The following is a description of a gene set: studied in species Homo sapiens part of: GPCR downstream signalling The classical role of the G-protein beta/gamma dimer was believed to be the inactivation of the alpha subunit, Gbeta/gamma was viewed as a negative regulator of Galpha signalling. It is now known that Gbeta/gamma subunits can directly modulate many effectors, including some also regulated by G alpha. Reactome Pathway: G-protein beta:gamma signalling, and this is the list of marker genes: GNGT1, GNG5, GNG7, GNG10, PIK3CG, GNG8, GNG12, PLCB2, GNB2, GNG11, GNG2, GNG4, GNGT2, ARHGEF6, PLCB3, AKT2, AKT1, GNG3, BTK, GNB5, PLCB1, GNB4, PIK3R6, AKT3, PIK3R5, RHOA, GNB1, GNB3 (NCBI Gene Id 2784), PDPK1, PAK1, CDC42, GNG13